Given this list of marker genes Rbl2, Ccn3, Ctsc, Ak1, Elf1, Adgre1, Map3k1, Rnf19a, Lilrb4b, Bnip3, Vamp5, Ak4, Cpe, Serpinf1, Cd53, Bcl2, Pfkp, Ifi211, Noct (NCBI Gene Id 99833), Ptgs2, Reps1, Zfp106, Tec, Spint1, Cd9, Tspan32, Ccng2, H1f0, Capn5, Bhlhe40, Enah, Lat2 (NCBI Gene Id 65021), Prdx4, Ptgir, Cd55, Pbx1, H2bc4, Sesn1, Calca, Gzmc, Rcn1, Sqstm1, Elovl6, Glb1, Net1 (NCBI Gene Id 78563), Fgf3, Fkbp1a, Hsd17b10, Galk1, Hk2, Tie1, Dhcr7, Il4, Ccl3, Slfn2, Snap23, S100a6, Cd55b, Anxa2, Tjp1, Crisp1, Dag1, Igfbp7, Slc39a6, Sparc, Scd1, Hmgcr, Aqp9, Msmo1, here is a description of the gene set: Mouse Gene Set: BRUNO_HEMATOPOIESIS Genes that are rapidly down-regulated as multipotential cells of the FDCP-mix hematopoiesis model undergo differentiation and loose their self-renewal and proliferation properties. species: Mus musculus The molecular mechanisms governing self-renewal, differentiation, and lineage specification remain unknown. Transcriptional profiling is likely to provide insight into these processes but, as yet, has been confined to static molecular profiles of stem and progenitors cells. We now provide a comprehensive, statistically robust, and dynamic analysis of multipotent hemopoietic progenitor cells undergoing self-renewal in response to interleukin-3 (IL-3) and multilineage differentiation in response to lineage-affiliated cytokines. Cells undergoing IL-3-dependent proliferative self-renewal displayed striking complexity, including expression of genes associated with different lineage programs, suggesting a highly responsive compartment poised to rapidly execute intrinsically or extrinsically initiated cell fate decisions. A remarkable general feature of early differentiation was a resolution of complexity through the downregulation of gene expression. Although effector genes characteristic of mature cells were upregulated late, coincident with morphological changes, lineage-specific changes in gene expression were observed prior to this, identifying genes which may provide early harbingers of unilineage commitment. Of particular interest were genes that displayed differential behavior irrespective of the lineage elaborated, many of which were rapidly downregulated within 4 to 8 h after exposure to a differentiation cue. These are likely to include genes important in self-renewal, the maintenance of multipotentiality, or the negative regulation of differentiation per se. from publication Bruno L, Hoffmann R, McBlane F, Brown J, Gupta R, Joshi C, Pearson S, Seidl T, Heyworth C, Enver T (PMID 14701746)